Given this list of marker genes P2RX7, GPR137, CD38, SFRP1, CSK, INPP5D, CARTPT, FSHR, IL6, IAPP, CST3, AGER, GPR137B, UBASH3B, CLDN18, GREM1, TNFAIP3 (TNF alpha induced protein 3), BCR, TMEM119, CALCA, YPEL4, PPARG, here is a description of the gene set: studied in species Homo sapiens Any process that stops, prevents, or reduces the frequency, rate, or extent of tissue remodeling. Human Gene Set: GOBP_NEGATIVE_REGULATION_OF_TISSUE_REMODELING